The following is a description of a gene set: Genes positively differentially expressed in cell type: pDC (plasmacytoid dendritic cell) upon treatment with cytokine: IFN-λ2 in mouse lymph nodes in vivo. Mouse Gene Set: CUI_PDC_IFNL2_RESPONSE_UP Cytokines mediate cell-cell communication in the immune system and represent important therapeutic targets. A myriad of studies have highlighted their central role in immune function, yet we lack a global view of the cellular responses of each immune cell type to each cytokine. To address this gap, the authors created the Immune Dictionary, a compendium of single-cell transcriptomic profiles of more than 17 immune cell types in response to each of 86 cytokines (>1,400 cytokine-cell type combinations) in mouse lymph nodes in vivo. A cytokine-centric view of the dictionary revealed that most cytokines induce highly cell-type-specific responses. For example, the inflammatory cytokine interleukin-1β induces distinct gene programmes in almost every cell type. A cell-type-centric view of the dictionary identified more than 66 cytokine-driven cellular polarization states across immune cell types, including previously uncharacterized states such as an interleukin-18-induced polyfunctional natural killer cell state. studied in species Mus musculus from publication Cui A, Huang T, Li S, Ma A, Pérez JL, Sander C, Keskin DB, Wu CJ, Fraenkel E, Hacohen N (PMID 38057668), and this is the list of marker genes: H2-Q6, B2m, Tmsb10, Ube2l6, Slfn5, H2-Ab1, H2-K1, Ly6a, Plaur, Irf7, Ifi27l2a, H2-D1, H2-Aa, H2-Q7 (NCBI Gene Id 15018)